Given this list of marker genes LEP, ACTA2, MYB, DDR2, RPS6KA1, here is a description of the gene set: Human Gene Set: GOBP_POSITIVE_REGULATION_OF_HEPATIC_STELLATE_CELL_ACTIVATION studied in species Homo sapiens Any process that activates or increases the frequency, rate or extent of hepatic stellate cell activation.